Given this list of marker genes Ubc, Ikbkg, Rps27a, Uba52rt (ubiquitin A-52 residue ribosomal protein fusion product 1, retrotransposed), Ube2n, Traf6, Peli3, Uba52, Ikbkb, Ubb, Peli1, Peli2, Irak1, Chuk, Ube2v1, here is a description of the gene set: IRAK1 recruits IKK complex studied in species Mus musculus Mouse Gene Set: REACTOME_IRAK1_RECRUITS_IKK_COMPLEX